The following is a description of a gene set: Human Gene Set: GOBP_REGULATION_OF_HIPPO_SIGNALING Any process that modulates the frequency, rate or extent of hippo signaling. studied in species Homo sapiens, and this is the list of marker genes: STRN4, AJUBA, SIRT1, MARK3, PPP2R1A, SOX11, NF2, VGLL4, NEK8, MOB3B, FRMD6, FRMD1, STRIP1, PPP2CA, STK4, MOB4, SLMAP, NUAK2, WWC2, SCHIP1 (NCBI Gene Id 29970), STK3, MAP4K4 (mitogen-activated protein kinase kinase kinase kinase 4), VCP, SIKE1, SHANK2 (NCBI Gene Id 654128), AARS1, ARRDC3, SRC, PRP4K, WWC1, CIT, YWHAE, MAP2K3, WTIP, CORO7, TIAL1, MAPK14, IQCJ-SCHIP1, WWC3, STRN3, LIMD1, DLG5